The following is a description of a gene set: The transcription factor FoxP3 partakes dominantly in the specification and function of FoxP3+ CD4+ T regulatory cells (Tregs), but is neither strictly necessary nor sufficient to determine the characteristic Treg transcriptional signature. Computational network inference and experimental testing assessed the contribution of several other transcription factors (TFs). Enforced expression of Helios or Xbp1 elicited specific signatures, but Eos, Irf4, Satb1, Lef1 and Gata1 elicited exactly the same outcome, synergizing with FoxP3 to activate most of the Treg signature, including key TFs, and enhancing FoxP3 occupancy at its genomic targets. Conversely, the Treg signature was robust to inactivation of any single cofactor. A redundant genetic switch thus locks-in the Treg phenotype, a model which accounts for several aspects of Treg physiology, differentiation and stability. studied in species Homo sapiens from publication Fu W, Ergun A, Lu T, Hill JA, Haxhinasto S, Fassett MS, Gazit R, Adoro S, Glimcher L, Chan S, Kastner P, Rossi D, Collins JJ, Mathis D, Benoist C (PMID 22961053) Genes up-regulated in CD4 T conv: control versus over-expression of LEF1 and FOXP3. Human Gene Set: GSE40274_CTRL_VS_FOXP3_AND_LEF1_TRANSDUCED_ACTIVATED_CD4_TCELL_UP, and this is the list of marker genes: BCAT1, ARL4D, TBC1D30, IER2, CITED2, TUBA1A, NT5E, PPFIBP1, KLHL3, SFXN3, TIGIT, LAG3, CES1, CYP2S1, LMO7, UBE2B, MARVELD1 (MARVEL domain containing 1), RTL3, TMC3, PRKCQ, CHST1, CCR4, PIM1, TNFSF14, GPR176, CD9, ADGRG5, SLC35B2, ITGAM, DMRTA1, SLC41A1, KLK8, CD27 (CD27 molecule), TMSB10, MBOAT1, GPR25, APOLD1, CCL5, MFHAS1, RASL11A, CD40LG, JAM2, LIPG, FAM120B, IL2RB, NCOR2, GZMB, CXCR3, ATP8A2, F3, ADORA2A, NKG7, EFNB2, GNB5, ADAMTS14, CXCR2, CD8B, IL18RAP, SARAF, PAK6, ITM2A, VEGFA, MVK, APRT, LRRC32, HGF, KLRC2, NFKBID (NFKB inhibitor delta), B4GALNT1, HK2 (NCBI Gene Id 3099), DHRS9, HOMER1, TOX, ITK, GDAP1, FEM1B, STX11, MIB2, GAD1, CTSW, MFSD2A, GOLGA8A, GLA, FAM110A, CD247, EOMES, C3AR1, MAP3K8, NAB2, SH2D1A, NFKBIZ, LEF1, AHNAK, MAFF, MRGPRE, LMO4, DAPL1, HEATR5A, PLCD3, HGSNAT, ALOX5, TTYH2, TNFAIP8, CD40, DUSP4, SKAP1, MOCOS, HS3ST3B1, SLC2A6, S1PR5, FGL2, NPY6R, LPAR2, B4GALT7, PMEPA1 (prostate transmembrane protein, androgen induced 1), SLC23A2, SYNE1, AACS, FAM174B, ZIC2, CACNB4, ELOVL5, IL10, RNF43, STK40, SERTAD2, QPRT, TGFB1I1, TNIK, TRAF4, MREG, MOV10, SLC12A7, S100A9, THY1, CLEC4D (NCBI Gene Id 338339), BACH1, GPR132, KLHL21, LAT (NCBI Gene Id 27040), ITGB1BP1, H1-6, APOBEC2, MMP9, GPR84, FABP1, SLC5A3, PLCXD2, CEBPD, CYP11A1, SP6, DUSP14 (dual specificity phosphatase 14), CRIM1, IL12RB2 (NCBI Gene Id 3595, interleukin 12 receptor subunit beta 2), CD300LB, SCML4, CSF3R, KCNA3, TNFRSF17, IFT140, HEYL, KDM2B, TNFRSF19, CTLA4 (NCBI Gene Id 3411), AGTRAP